Given this list of marker genes Gfi1, Ptpn2, Il6st, C1qtnf4, Ripk1, here is a description of the gene set: Any process that modulates the rate, frequency or extent of an interleukin-6-mediated signaling pathway. species: Mus musculus Mouse Gene Set: GOBP_REGULATION_OF_INTERLEUKIN_6_MEDIATED_SIGNALING_PATHWAY